Given this list of marker genes DGUOK, NAPRT (nicotinate phosphoribosyltransferase), CDA, ADSL (NCBI Gene Id 158), AMPD3, ADK, DCK, AMPD2, APRT, UCKL1, UPP1, ADA, UPP2, ADSS1, UCK1, HPRT1, AMPD1, UCK2, here is a description of the gene set: Human Gene Set: GOBP_NUCLEOTIDE_SALVAGE studied in species Homo sapiens Any process which produces a nucleotide, a compound consisting of a nucleoside that is esterified with (ortho)phosphate or an oligophosphate at any hydroxyl group on the glycose moiety, from derivatives of it without de novo synthesis.